The following is a description of a gene set: from publication Tabula Muris Consortium (PMID 32669714) Mouse Gene Set: TABULA_MURIS_SENIS_GONADAL_ADIPOSE_TISSUE_ENDOTHELIAL_CELL_AGEING studied in species Mus musculus, and this is the list of marker genes: Rsrc2, Rps5, Dcn, Ubxn1, Emc6, Fam76a, Gnpnat1, Krt14, Qdpr, Plpp3, Calm1, Snx21, Vps29, Gpihbp1, Dnajc1, Ptp4a2 (NCBI Gene Id 19244), Ctsh, Saraf, Mbd2, Tpm3, Stk10, Gtf2b, Krt6a, Slc66a2, Myl12b, Sub1 (SUB1 homolog, transcriptional regulator), Rad1, Fam32a, Pnrc1, Serpinh1, Cemip2, Psmb1, Med13l, Stam2, Cox5a, Fxyd5, Ift20, Phf11d, Clic4, Braf, Scyl2, Hacd2, Tmem242, Dhx9, Prmt1, St6galnac2, Tspan13, Cox11, Nufip2, Gnb1, Hspe1, Aldh7a1, Hmg20b, Mnat1, Swi5, Pfdn5, Ssr4, Lum, Clta, Kmt2b, Mrpl49, Arhgdib, Npc2, Naca, Oard1, Otub1, Ddx50, Magoh, Hpcal1, Coro1a, Mxd4, Fibp, Nherf2, Rps10, Actr10, Med27, Lamtor3, Emc2, Fmnl3, Abhd17a, Ywhah, Gbp7, Polr1g (NCBI Gene Id 70333), Mrpl48 (mitochondrial ribosomal protein L48), Hras, Pex14, Tmem59, Tmco1, Rab5if, Ttc28, Srsf2, Rbmxl1, Rp9, Pin1, Snrnp70, Zfand5, Itpa, Spcs1, Mrpl42, Bad, Tmem14c, Scarb2, Ncor1, Coa3, Il18bp, Cd74, Erp29, Dhcr24, Tmem250, 9530082P21Rik, Tomm40l, Brk1, Abcg1, Znhit1, Eif1b, Ube2j1 (ubiquitin-conjugating enzyme E2J 1), Slf2, Cox7a2l, Tbrg1, Clec9a, Pcbp2, Mgll, Twf1, Fbxl14, Dctn3 (dynactin 3), Ndufb7, Pttg1 (NCBI Gene Id 98125), Arhgap31, Nop56, Rhoc, Rpl8, Rps7, Mettl9, Nfkbia, Srsf6, Map7d1, Ttc32, Oaz1, Rrp36, Ppp1r13l, Vamp8, Imp3, Mrps15, Dpy30, Fth1, Ifi35, Arpc2, Id1, Syf2, H2az2, Adprh, Elof1, Rnf181, Pyy, Bccip, Arid5b, Pkig, Acap2, Rac2, Cyp4b1, Zcchc8, Gsn, Lamtor5, Mpp4, Ctnnbip1, Psme2, Sod2, Gemin7, Dpt, Ifitm2, Mrps36, Nudt9, Ndufa13, Cgrrf1, Arpc5l, Cops7a, Syngr2, Rtl8b, Igtp, Tecr, Rsbn1, Fuca1 (fucosidase, alpha-L- 1, tissue), Pcnp, Dtx3, Ddrgk1, Cd14, Snx24 (sorting nexing 24), Eif3k, Atp8a1, Prdx1, Edf1, Vrk3, Nedd8, Col3a1, Dhrs3, Ecm1, Fkbp8, Cd36, Serpinb1a (serine (or cysteine) peptidase inhibitor, clade B, member 1a), Abi3, Cd300lg, Rassf1, Atoh8, Lsm2, Brd1, Cript, Borcs8, Tgtp1 (T cell specific GTPase 1), Kif5b, Ptk2, Psmd4, Vps28, Trim47, Neat1, Necap2, Rilpl1, BC031181, Ccz1, Ceacam1, Emcn, Abcf1, Arl6ip5 (ADP-ribosylation factor-like 6 interacting protein 5), Tpd52, Fam3c, Tceal8, Atp5f1d, Smpdl3a, Rpl3, Ccdc124, Snapc5, Kpna3, Psmd7, Pop5, Snx3, Mrps26, Polr2i, Ssb, Rpl17, Atp2b1, Serinc5, S100a16, Inppl1, Elovl1, Atp6v1g1, Ctss, Bcl3, Ctsl, Pea15a, Smagp, Csrp1, Rps3, Lysmd2, H1f0, Map1lc3a, Spred3, Mitd1, Galk1, Peak1, Igfbp7, Med28, Rps9, Nsmce2, Gbf1, Vps72, Ccnl2, Lims2, Psmc2, Dph5, Tceal9, Rtf1, Cfl1, Selplg, Hapstr1, Ube2e1, Cfdp1, Dcaf13, Flrt3, Zmynd8, Itm2b, Ptpn11, Ube2m, Sox4, Zmat5, Exosc8, Aamp, Paip2, Cyba, Tsg101, Inip, Ssr2, Luzp1, Chaserr, Utp23, Nfu1, Dlgap4, Nmd3, Commd3, Nat9 (NCBI Gene Id 66176), Dab2ip, Psma3 (proteasome subunit alpha 3), Gnb2, Ccdc71, Naa10, Pik3r3, Tmem50a, Camk2n1, Cdc42ep3, Lyar, Mxra7, Pgls, Myl12a, Msl1, Dctn5, Psmb5, Tpr, Selenom, Bsg, Smc6, Efcab14, Psme4, Mrtfb, Vamp4, Zfyve27, Tle5, Dcp1a, Polr2e, Sdhc, Clic1, Faim, 5031425E22Rik (RIKEN cDNA 5031425E22 gene), Rpsa (ribosomal protein SA), Exosc5, Arhgdia, Hmox2 (NCBI Gene Id 15369), Fry, Alg14, Tes, Rbm39, Pcf11, Tubb4b, 2310033P09Rik, Xaf1, Gstt2, Cybb, Rbm42, Plin3, Psma2, Nras, Birc6, Cdc123, Etfb, Psip1, Rnps1, S100a13, Tuba1a, Sox18, Efemp1, Cd81, Chmp2a, Col15a1, Eef2kmt, Eed, Dyrk1a, Agl, Tbca, Ubqln4, Uqcrfs1, Caml, Zfpl1, Vti1b, Cbx1 (NCBI Gene Id 319869), Use1, Pfdn2, Lyz2, Wdr45, Tm4sf1, Snrpd3, Rabep1, Trappc6b (NCBI Gene Id 96981), Eva1b, Shisa5, Gng11 (guanine nucleotide binding protein (G protein), gamma 11), Trp53inp1, Tektip1, Pdpr, Chic2, Limd2, Dtd1, Arid1b, Vapb, H2-K1, Dynlrb1 (NCBI Gene Id 99273), Vamp2, Gabarapl2, Rps11, Tex261, Stx4a, Vkorc1, Ctsz (NCBI Gene Id 99199), Commd10, Calm2, Morf4l1, Leng1, Dazap2, Pno1, Purb, Rrp1, Cltb, Ercc1, Psph, Slc25a4, Trim56, Tnfsf12, Hexb, Atraid, Rbm8a, Csnk2a2, Gprc5b, Dpysl2, BC004004, Tprg1l, Gstm1, Mcmbp, Ubb-ps, Fus, Banf1 (NCBI Gene Id 98145), Ranbp1, Hnrnpa0, Mettl21a, Nme2, Uri1, Malat1, Nub1, Ftl1, Zcrb1, Emc4, C130074G19Rik, Dip2c, Ppib, Fbxo6, Smap1, Stub1, C3, Sh3glb1, Gabarap, Nop53, Mdh1, Zscan26, Mtarc2, Aurkaip1, Sec11a, Rpl27a, Fryl, Psma5, Ncbp2as2, Thrsp, Foxk1, Pebp1, Cytl1, Frg1, Rheb, Smim14, Bbs9, H2bc4, Mrps7, Psmd12, Dhx33, Usp19, Tusc2, Ifnar1, Aup1, Ube2v1, Mrps14, Klhl6, Mrpl51, Tomm6, Tor1aip1, Snrpb, Oaz2, Ube2s, Phkg2, H2-D1, Abcb1b, Litaf, Adap2, A330023F24Rik, Ndfip1, Fam89b, Vcf1, Atxn7l3b, Zfp622, Atp5pb, Nsd3, Nfkbil1, Rgcc, Kdm6b, Cask, Clock, Myh9, Kdelr1, Rps3a1, Asxl1, Anxa3, Brd3, Hnrnpl, Dcbld2, Txnl4a, Ctdnep1, Yy1 (YY1 transcription factor), Surf1, Slc25a3, H2-Eb1, Psme1, Gnai2, Klhl20, Jund, Tmem184c, Srsf11, Sbds, Arl3, Klf7, Clint1, Rbm26, Gpx8, Ssr1, Ociad1, Cldn5, Ptms, Lrrfip1, Raly, Taf10, Rpl24, Samm50, Pltp, Cacybp, Cnnm3, Eno1b, Kpna4, Cbfa2t3, Eci2, Ppp4c, Pdcd10, Eif2s1, Arf6, Cdk9, Abhd5, Ift27, Gm15441, Ywhae, Anxa11, Trir, Laptm5, Sparc, Pgd, Rabac1, Irf2bpl, Il3ra, Eif3g, Tmem259, Set, Fis1, Anks1, Serpinf1, Ltbr, Furin, H2-Aa, Naa38, Mtrex, Rps24, Hs6st1, Stk11, Ldb1 (NCBI Gene Id 16825), Retsat, Ndufs3, Ebna1bp2, Dynll2, Pdia6, Nacc1, Denr, Cmtm3, Polr2g, Trabd2b, Ddah2, Ddhd2, Lias (lipoic acid synthetase), Psmb8, Prelid3b, Plekhm2, Sgf29, 2210016L21Rik, Brd4 (NCBI Gene Id 57261), Gga1, Rdx, Ece1, Stk19, Slc50a1, Slbp, Cep350, Zbtb22, Tmem223, Spr, Sys1, Wasf2, C1d, Mmp2, Commd1, Depp1, Tmem263, Smc1a, Rpl34, Ripor1, Tagln2 (transgelin 2), Uso1 (USO1 vesicle docking factor), Camk1 (NCBI Gene Id 52163, calcium/calmodulin-dependent protein kinase I), Rbms1, Cdc5l, Tlr2, Ppa1, Rpn1, Rpl14, Myct1, Hoxd3, Tbcb, Spag7, Atxn1, Scand1, Spag9, Pnp, Cnpy2, Ap2s1, Snw1, Ifi203, Srek1, Ctbp2, Ier2, Eif5a, Gpx4, Dda1, Ctla2a, Dnajc8, Cops6, Hnrnpd, Aktip, Dhrs7, Pitpna, Srp9, Filip1l, Ube2g2 (ubiquitin-conjugating enzyme E2G 2), Ube2l3, Cuedc1, Tbpl1, Prickle3, Egfl7, Phb1, Sacm1l, Ppp1ca, Efna1, Cnpy3, Washc3, Rbm25 (RNA binding motif protein 25), Snrnp27, Foxn3, Msra, Btf3, Rplp0, Tmed9, Irf7, Skap2, Sars1, Med4, Rab5c, Tmem234, AW554918, Fam181b, Nsfl1c, Ergic3, Sumo1, Mrpl30, Tspo, Prr13, Skil, Marf1, Rnf125, Baiap2, Mgst1, Gch1, Atp6v0c, Nudt3, Luc7l3, Kif24, Ankrd12, Hspb8, Hmgb1, Rnaset2b, Ssbp3, Npm1, Tmem86a, Rbm34, Adrm1, Id3, Rin3, Yeats2, Ahsa1, Mrps33, Smarce1, Gpr89, Inafm2, Abhd16a, Cdkn1c, Nfkbib (nuclear factor of kappa light polypeptide gene enhancer in B cells inhibitor, beta), Gatad2b, Pde4b, Tmem160, Snrpc, Dkk3, Klf13, Tm2d3, Tlnrd1, Sfr1, Rpl13a, Ppp1r11, Sltm, Pisd, Praf2, Rab11b, Stmn1, Arpc1b, Cd59a, Atg101, Pias1, Timm23, Mdp1, B2m, Mtdh, Hmgn1 (high mobility group nucleosomal binding domain 1), Pold2, Rras, Gpx3, Krt15, Alg5, Map4k3, Pard3, Arhgap5, Cuta, Prdx5, Skic3, Trp53rka, Chd1, Eri3, Ly6c1, Lpl, Car4 (carbonic anhydrase 4), Krt5, Nprl2, Rps20, Arpc3, Psmb9, Bnip3l, Idnk, Gstt1, Aimp1, Ralgapa2, Rexo2, Rps4x, Ddhd1, Mvb12b, Prdx4, Crip2, Ubl7, Ppid (NCBI Gene Id 67738), Ostf1 (NCBI Gene Id 98144), Trf, Usp7, Hspa4, Selenow, Zfand6, Maff, Spp1, Creb3, Dpm1, Dkc1, Mydgf, Mepce, Tcf7l2, Picalm, Tmsb10, Pomp (NCBI Gene Id 66537), Spcs2, Tpt1, Grap, Rpl9, Ppig, Hprt1, Wdr82, Lman2, Prrg2, Rnf170, Magee1, Med19, Psmb10, Tcf15, Pih1d1, Psmc5, Dysf, Dad1, Ech1, Lamtor4, Ilkap, Nrgn, Cib1, Phb2, Farsb, Pak1ip1, Babam2, Mea1 (NCBI Gene Id 17256), Inmt, Selenok, Bloc1s4, Particl, Smco4, Bcl7c, Ppp2r3d, Dusp3, Hsp90aa1, Rtn4, Park7, Gda, Ppp1r18, Psmc3, Eif2ak2, Trmt10b, H2-Q4, Lgals3bp, Dpagt1, Timm44, Gfpt2, Tubb2a, Numa1, Ing1, Rap1a (RAS-related protein 1a), Atp5pd, Timm13, Ube2d1, Kmt2e, Usp12, Arf5, Tpgs1, Arpc1a, 4930413G21Rik, Card19, Hes1, Cibar1, Capns1, Zfp36, Cmtm8, Gclm, Ube2k, 5830417I10Rik, Laptm4a, Dnajc19, Fubp1, Ndufb5, Gna11, Vasp, Smarcc1, Tkt, Arpc4, Zfp609, Pdgfb, Dennd5b (NCBI Gene Id 320560), Ostc, Clip1, Pank2, Tgtp2, Inka1, Mettl17, Wbp2, Emc10, Nrros (negative regulator of reactive oxygen species), Smarcb1, St13, Slc35a5, Orai1 (ORAI calcium release-activated calcium modulator 1), Akap8l, Smim30, Letmd1, Tmem205, Cavin1, Heatr5b, Cnbp, Slc25a19, Mast3, Arrb1, Itpripl1, Arhgef40, Snrpa1, Sf3b4, Acp6, Ubxn4, Kptn, Pfn1, Grina (glutamate receptor, ionotropic, N-methyl D-aspartate-associated protein 1 (glutamate binding)), Rack1, Gstm2, Cirbp, Vamp5, Irf1 (interferon regulatory factor 1), Tmem87b, Nfic, Bola3, Reep5, Ccdc85b, Ecscr (NCBI Gene Id 68545), Hspb1, Dap3, Trim2, Anp32a, Gon4l, Rnaseh2c, Spring1 (NCBI Gene Id 76792), AW112010 (expressed sequence AW112010), Cdkn1a, Tpst1, Rpl13, Cdc27, Copz2, Lrrc8a, Tra2a, Med25, Ly6a, Mrfap1, Ddit4, Antkmt, Ypel3, Arl6ip1, Csf1r, Dek, Stard3nl, Tm2d1, Rnf167, Samhd1, Apoe, Il1r1, Tspan17, Taf12, 1110038F14Rik (NCBI Gene Id 117171), Lgals9, Ggh, Pde4d, Igf2bp3, Srsf5, Hhex, Cplane1, Eif6, Snrpa, Eif4e3, Serbp1, Sarnp, Stk35, Manf, Kif1c, Ptma, Amer1, Tmed10, Gapdh, Lyset, Ccdc88c, Ybx1, Dgkz, Dnajc7, Srsf7, Icam2, Pde6d, Lamtor1, Nabp2, Ncl, Hrct1, Polr1d (NCBI Gene Id 97252), Ndufs4, Tmem88, Fam162a, Ldlrad3, Slc4a7, Rnd1, Drap1, Cd63, Nucb2, Dmxl1, Tsn, Map3k2, Khdrbs3, Bri3, Snf8, Szrd1, Inpp4a, Taf1a, Bex3, Timm8b, Larp1b, Pdhb, Dph6, H2-Ab1, Ptpn23, BC005624, Tmbim4, Naxe, Cd44, Bckdha (branched chain ketoacid dehydrogenase E1, alpha polypeptide), Fabp4, Tmsb4x, Med10 (NCBI Gene Id 97867), Cacna2d1, Mocs2, Cycs, Mgp, Glmp, Anapc11, Hax1, Chtop, Iffo2, Copz1, Kansl1l, Hpf1, Imp4, Atp6v0e, Rer1, Mia2, Ctcf, Rpl6 (ribosomal protein L6), Chmp5, Eif1ax, Itpr2, Polr1h, Gatd3a, Bst2, Tmed5, Akap9, Col1a2, Mrps24, Ccng1, Ogn, Odr4, Pdlim7, Ccdc25, Mfn2, Capg, Atp5f1c, Bambi-ps1, Erh, Srsf10, Gstp1